Given this list of marker genes PSMB2, PSMD11, BTRC, PSMA6, PSMA3, PSMA4, PSMB5, PSMD14, UBE2D1, CUL1 (cullin 1), PSMC2, UBB, RBX1, SEM1, RPS27A, PER2, PSMB7, PSMD12, PSMB1, PSMC5, PSMD8, FBXW11, PSMD6 (NCBI Gene Id 9861), PSMD1, PSMC1, PSMB6, CRY2, PSMB3, PSMA7, FBXL3, PSMD3, PSMA5, PSMD7 (NCBI Gene Id 5713), CRY1, PSMB4, ADRM1 (NCBI Gene Id 11047), PSMD13, PSMD2, UBA52, PER3 (period circadian regulator 3), PSMC3, PER1, PSMA2, PSMA1, PSMC6, SKP1, UBC, PSMC4, here is a description of the gene set: Degradation of CRY and PER proteins studied in species Homo sapiens Human Gene Set: REACTOME_DEGRADATION_OF_CRY_AND_PER_PROTEINS